Given this list of marker genes MAD2L1, ASPM, KIF11, CENPA, MELK, TPX2, PRKDC, RRS1, BUB1B, ARMC1 (armadillo repeat containing 1), NCAPG, ESRP1, CEP55, KIF4A, RB1CC1, MCM4, BUB1, MTFR1, NEK2, SLC25A32, KIF15, PRC1, RAD54B, MRPL15, NDC80, CENPE, ATAD2, CCNA2, PTTG1, NUSAP1, CCNB2, MTERF3, KIF20A, here is a description of the gene set: Human Gene Set: FARMER_BREAST_CANCER_CLUSTER_2 Previous microarray studies on breast cancer identified multiple tumour classes, of which the most prominent, named luminal and basal, differ in expression of the oestrogen receptor alpha gene (ER). We report here the identification of a group of breast tumours with increased androgen signalling and a 'molecular apocrine' gene expression profile. Tumour samples from 49 patients with large operable or locally advanced breast cancers were tested on Affymetrix U133A gene expression microarrays. Principal components analysis and hierarchical clustering split the tumours into three groups: basal, luminal and a group we call molecular apocrine. All of the molecular apocrine tumours have strong apocrine features on histological examination (P=0.0002). The molecular apocrine group is androgen receptor (AR) positive and contains all of the ER-negative tumours outside the basal group. Kolmogorov-Smirnov testing indicates that oestrogen signalling is most active in the luminal group, and androgen signalling is most active in the molecular apocrine group. ERBB2 amplification is commoner in the molecular apocrine than the other groups. Genes that best split the three groups were identified by Wilcoxon test. Correlation of the average expression profile of these genes in our data with the expression profile of individual tumours in four published breast cancer studies suggest that molecular apocrine tumours represent 8-14% of tumours in these studies. Our data show that it is possible with microarray data to divide mammary tumour cells into three groups based on steroid receptor activity: luminal (ER+ AR+), basal (ER- AR-) and molecular apocrine (ER- AR+). species: Homo sapiens from publication Farmer P, Bonnefoi H, Becette V, Tubiana-Hulin M, Fumoleau P, Larsimont D, Macgrogan G, Bergh J, Cameron D, Goldstein D, Duss S, Nicoulaz AL, Brisken C, Fiche M, Delorenzi M, Iggo R (PMID 15897907) Cluster 2: selected proliferation and 8q amplicon genes clustered together across breast cancer samples.